Given this list of marker genes Cdc5lrt5, Cdc5lrt10, Cdc5lrt7, Cdc5lrt9, Cdc5lrt1, Cdc5lrt8, Cdc5lrt6, Cdc5lrt4, Cdc5l, here is a description of the gene set: Mouse Gene Set: GOBP_CELLULAR_RESPONSE_TO_WORTMANNIN studied in species Mus musculus Any process that results in a change in state or activity of a cell (in terms of movement, secretion, enzyme production, gene expression, etc.) as a result of a wortmannin stimulus.